The following is a description of a gene set: from publication Chen Y, Wang X (PMID 31504780) species: Homo sapiens Human Gene Set: MIR19B_3P Genes predicted to be targets of miRBase v22 microRNA hsa-miR-19b-3p in miRDB v6.0 with MirTarget v4 prediction scores > 80 (high confidence targets)., and this is the list of marker genes: F3, DNAI1, DSEL, PHF12, VTI1A, FAM43A, CREBRF, BLCAP, SLC24A3, PFN2, TAOK1, LY75, PIK3CB, HDLBP, RABGAP1, PPARA, CNGA3, PHLDA3, DCBLD2, ABCB7, BRWD1, PLS1, MACF1 (NCBI Gene Id 649183), PCDH15, MTMR6, S100PBP, WBP4, WDR1, PRC1, MDFIC, ZNF469, HOMER1, PLAA, DDX3X, GOLGA6B, NFIB, MIER1, SLC6A6, ZBTB11, ZNF367, ASXL2, SIPA1L1, DCUN1D3, RAB21, PDIK1L, MOSMO, KIAA2013, TXLNA, HIC1, SPATA2, SERPINB12, SF3B3, MEF2A, DPYSL5, PCDH10, RBMS3, MBD2, ITSN1, MTCL2, SMCR8, BMP3, RNF145, RAP2C, CACUL1, PARPBP, PIK3R3, ATXN1, DNAAF9, ZNF716, WDFY3, VPS37A, TENT5A, TSHZ3, SLC9A6, WDR26, NALF1, USP12, ADCY9, SESN3, CYP2U1, CNOT7, PIK3CA, EBF2, RAB14, PRKAA1, ARRDC4, LDLR, SYN1, KCNA4, HNRNPUL2, KLF13, NAALADL2, MBNL2, MECOM, LSM12, CEP350, PPP2R5E, NLK (nemo like kinase), MTCL1, MBNL3, TMEM47, GIT2, ZNF516, LRRTM2, MKRN1, GIGYF1, RORA, DLX3, BAG5, TGIF1, NEUROD1, TBR1, CCDC6, ZMYND11, PDE5A, PRRT3, MAPK8, EDARADD, ERBB4, TNFAIP3, EYA1, GPR137B, ATL2, ATP6V1B2, SH3KBP1, FAM114A1, FAM234A, E2F8, CEP55, CDC42BPA, ACSL4, ZNF831, BPTF, ARHGAP11A, ST8SIA3, CNKSR2, MAB21L2, AQP5, CCDC88A, EREG (NCBI Gene Id 2069), TGM3, TAF4, DDX3Y, SATB1, MECP2, TIA1, RAP1B, FBXO8, RACGAP1, CBLN2 (NCBI Gene Id 870), MPHOSPH9, NBEAL2, ACADSB, LRIG1, PLXNC1, EOGT, IL15, CAMSAP1 (calmodulin regulated spectrin associated protein 1), SLC12A7, SRGAP2B, SOX6, SEPTIN7, AMMECR1L, FAM76B, ASAP2, MMGT1, PCDHA4, MSI2, SV2A, AUH, CCND2, CAMSAP2, CASTOR2, WDR44, ID2, SIVA1, MED26, C2CD5, REST, FAM168A, CRACD, ANKRD29, ELOVL5, SYT11, CCNA2, NRBP1, ZFP91, ZNF518A, VPS4B, KPNA3, ADCY7, CGN, NR3C2, CNOT6L, VAMP3 (vesicle associated membrane protein 3), BTF3L4, SMAD5, PHTF2, LRP2BP, KCNC4, PI15, SEC11A, TNFRSF12A, ARC, MED12L, SMARCA2, ACBD5, HIPK3, TFCP2L1, CLTC, OTUD7B, PCDHA11 (NCBI Gene Id 56138), SNTG1, IMPDH1, MATN3, ACTN1, CD164, USP8, HECW2, KHDC4, ZNF445, STK32B, ST3GAL5, SRGAP2C, PGM2L1, PCDHA1, ZDHHC18, MDM1, TMEM45A, FHIP1A, ARAP2, KIF3A, TNRC6C, FOXP1, DNAJB1, SBF2, RAPGEF2, SLC35F1 (NCBI Gene Id 222553), PON2, CNOT6, ZBTB18 (NCBI Gene Id 10472), WAC, GRAMD1B, ZFYVE26, PCDHAC1, CCNT2, ARPP19, ATG14, FOXP2, PRR5L, ARSD, RBCK1, S1PR1, MIGA2, PCDHA8, PYGO2, ETV5, ERBB3, ARHGAP21, CYLD, CACNA1C, TENT2, PPTC7, AKAP1, EMX2, PTPRG, CLOCK, EHBP1, SKIL, DDX6, CFL2, DOCK4, WBP1L, ATG16L1, TCIM, SEC61A2, JRKL, RNF11, KLHL20, TRIM23, SIN3B, AFTPH, DBN1, PCDH7, WDR20, CCNL1, BNIP2, CHIC1, GTF2H1, ATXN1L, LRP2, EPN2, RAP1A, DOCK10, RPS6KA5, CAPRIN2, VPS35, GTF2A1, GAREM1 (GRB2 associated regulator of MAPK1 subtype 1), SOS2, ABHD17C, ARFGEF1, ATXN7, IFI44L, ARMC8, MICAL2, GET3, SULF1, HNRNPUL1, FBXO32, EXOC5, SAMD8, YTHDF2, SLC31A2, PCDHA2, IGF1, MAPK1, GSC, UBE2D3, DOCK3, RCOR1, MPPED2, ATP10A, INO80D, BTG1, MED13, FNDC3A, PLXNA4, ATF2, FRMD4A, IGFBP3, ARHGAP12, HERC4, CLIP4, ADCY1, RAPGEF4, FKBP15, SOCS1, RHEBL1, PARP8, ABHD5, PCDHA10, TNFRSF11A, SIX4, SDC1, PSAP, RAF1, MAGI2, TBK1 (NCBI Gene Id 29110), RALGPS1, BTAF1, HIPK1, CCND1, RNF44, CAND1, ZBTB46 (zinc finger and BTB domain containing 46), PPP1R12A, RFX4 (regulatory factor X4), NME7, SLC25A6, IL26, SNX17, FAT3, BNC2, CHST1, ITGA6, PRUNE2, RAB18, CBX6 (NCBI Gene Id 23466), MID1, RTN1, GTDC1, B4GALT5, DNAJA2, SGK1, SEL1L, ENC1, TET3, LIMCH1, UBL3, POU4F1, LRIG3, PITX1, RAI2, CASP10, ENPP5, LIN9, SMOC1, TSC1, ABR, DICER1, SRSF6, ITCH, PMEPA1, MLLT6, SLC4A7 (NCBI Gene Id 9497), G3BP2, IVNS1ABP, SUZ12, PHF13, GSKIP, TNKS, CDS1, MAPK6, KLHL11, SMURF1, SAMD4A, PCDHA5, GPCPD1, SLC2A13, OTUD1, CCDC126, SEMA4C, RGL1 (NCBI Gene Id 23179), ZMAT3, GRK6, SHANK1, RBMS1, ELMOD2, LONRF1, SCUBE3, BAMBI, SKIDA1, WDR45B, PLCB1, HBP1, SOCS5, ACOX3, AGPAT5, PCDHA6, UBE2A, EPS15, DIPK1A, CAST, RBBP8, KLF10, DLG5, SPOCK1, NPEPL1, TENT5B, PCDHA7, CCSER2, PTEN, BTBD7, SHCBP1, ZNF680, MFSD6, ZER1, FAM83D, YIPF6, C11orf96, CSMD1, MYCN, RAB1A, PCDHA9, DLC1, JADE1 (NCBI Gene Id 79960), DUSP7, PATL1, ZNF827, GULP1, PCDHA3, MBD6, PSG1 (pregnancy specific beta-1-glycoprotein 1), FASTK, PAK6, RNF111, ABCA1, KPNA6, ADSS2, ARIH2, ANKIB1, ROBO2, OSBPL11, RUNX2 (RUNX family transcription factor 2), KLF7, MAP3K1, RAB8B, ZDHHC23, KCNJ2, FLNC, ATP6V0E1, SLC16A7, REEP3, ANO1, PGR, SLC6A8, SCN3A, RASSF2 (Ras association domain family member 2), ITGB8, HCFC2, COX8C, FMR1, MOB1B, ELL2, TRIM33, DMXL2, UBE2D2, SLC6A11, ZNF521, CHD2, USP33, ZNF644, ZNF385B, PPFIA2, NDFIP2, NRK, ZBTB4, DENND6A, NCKAP5 (NCK associated protein 5), PCDHA13, KIAA1217, ARFIP1, MSMO1, ATP2C1, GRSF1 (G-rich RNA sequence binding factor 1), C2orf42, BEND4, ROR1, SERPINE1, TTC9 (NCBI Gene Id 23508), TNPO2, TMEM64, RIN2, B3GALNT2, CCPG1, BEND3, PITPNM2, FZD6, ZBTB20, SYT1, KBTBD8, SLC37A1, EIF4G2, SH3D19, USP13, MAP4K3, SPTSSB, POU3F2, ATP12A, KIF13A, ADRB1, GRIN2A, STOX2, ZNF609, MGAT5, EFNB2, PNRC1, CLIP1, SP100, PDE3B, ZBTB10, AFF1, ZNF217, BRWD3, KRTAP3-1, ZFYVE9, WNT3, MAP3K2, MEX3C, MAPK14, RICTOR, HPRT1, DESI2, ANKRD42, SOX4, FUT9, MDM4, WNK1, ADIPOR2, PRKACB, ZBTB14, NAPB, SOCS3, PRICKLE2, TMBIM6, MEMO1, ZNRF3, RNF216, NPTN, TNRC6B, VSTM2B, EEIG1, ABCC3, STK26, CAB39, QKI, SYNM, LONRF3, BMPR2, GJA1, ATXN7L1, SOX5, RIMKLA, ARRDC3, NUP54, DNAJC16, UHMK1, JAZF1, ZDHHC7, MRTFB, RHOB, CPD, RNF167, SLC49A4, POSTN (NCBI Gene Id 10631), HIP1, KCNQ5 (potassium voltage-gated channel subfamily Q member 5), N6AMT1 (NCBI Gene Id 29104), CNTFR, GABARAPL1, MAP3K12, ESR1, APPL1, ADNP, SERINC3, NPAS2, SECISBP2L, NFIA, EMC7, PCDHAC2, NAP1L2, P3R3URF-PIK3R3, MYCL, EPHX4, ATP11A, PKNOX1, NFIC, ITGA2, PHF14, DTNA, STK35, PTPRD, SLC26A7, NAV3, PCDHA12, GRM1, CBLB (NCBI Gene Id 868), KLHL42, MTRR (NCBI Gene Id 4552, 5-methyltetrahydrofolate-homocysteine methyltransferase reductase), LLGL2, THSD7A (thrombospondin type 1 domain containing 7A), FBXO48, SMG1, EXOC6B, CCM2, ZNF320, GOLGA6A, MB21D2, LGALSL (galectin like), TUB